Given this list of marker genes AXIN1, DGUOK, APC, ARG1, KIF3B, POLG, TALDO1, PIGA, MET, ATP6AP2, ZFYVE19, NGLY1, PIK3CA, CASP8, KRT18, TP53, ABHD5, IGF2R, CTNNB1, PDGFRL, TREX1, MPV17, SLC30A10, here is a description of the gene set: Micronodular cirrhosis studied in species Homo sapiens A type of cirrhosis characterized by the presence of small regenerative nodules. Human Gene Set: HP_MICRONODULAR_CIRRHOSIS